The following is a description of a gene set: from publication Xie X, Lu J, Kulbokas EJ, Golub TR, Mootha V, Lindblad-Toh K, Lander ES, Kellis M (PMID 15735639) Comprehensive identification of all functional elements encoded in the human genome is a fundamental need in biomedical research. Here, we present a comparative analysis of the human, mouse, rat and dog genomes to create a systematic catalogue of common regulatory motifs in promoters and 3' untranslated regions (3' UTRs). The promoter analysis yields 174 candidate motifs, including most previously known transcription-factor binding sites and 105 new motifs. The 3'-UTR analysis yields 106 motifs likely to be involved in post-transcriptional regulation. Nearly one-half are associated with microRNAs (miRNAs), leading to the discovery of many new miRNA genes and their likely target genes. Our results suggest that previous estimates of the number of human miRNA genes were low, and that miRNAs regulate at least 20% of human genes. The overall results provide a systematic view of gene regulation in the human, which will be refined as additional mammalian genomes become available. Genes having at least one occurrence of the highly conserved motif M85 STTTCRNTTT in the regions spanning 4 kb centered on their transcription starting sites. This matches the transcription factor binding site V$IRF_Q6 (v7.4 TRANSFAC). species: Homo sapiens Human Gene Set: STTTCRNTTT_IRF_Q6, and this is the list of marker genes: PSME1, ELOA2, HGF, ECM2 (NCBI Gene Id 1842), UBA7, CAPRIN1, BHLHE41, USP44, CCND1, PSMB8, ITGB7, TCIRG1, IL4, DDR2, PTK2, NFIX, RNF31, NAMPT, VGLL4, ARHGAP5, E2F3, SFMBT1, LGALS3BP, MSX1, COL4A1, LSM6, SEPTIN9, DLX4, CCDC6, ETV6, COLCA1, PIGR, ELK4 (NCBI Gene Id 2005), RIGI, KLHL13, TRIM21, LGI1, CDK12, IKZF2, OSM, PIK3R3, COL4A2 (NCBI Gene Id 1284), MED13, DYNLT1, PSMB9, NAV3, IFNB1, IL12RB1, CHGB, PSIP1, EDIL3, NCF1, ZNF366, VAMP5, IL18BP, AMER1, CLDN3, GSX1 (NCBI Gene Id 219409), MRPS18B, IL22RA1, BST2, USF1, ADAM12, YWHAG, PSMA5, HOXA13, CBX4, TCF15, OTX1, OSR2, HPCAL1, CIITA, CTTNBP2NL, EPSTI1, CASP1, ASXL1, MLLT3, SORBS1, FEZF2, SATB2, MOV10, PKN2, MAP3K11, BCL11A, NFATC1, BCL2L1, TCF12, CITED2, IRAG2, ZNF503, SLC15A3, DHX58, TRPM3, NOD2, NRG1, CDK6, JADE2, NR3C2, ISG15, SLC25A28, ALDH1A1, RAPGEF6, ZDHHC14, EIF5A, EVL, CREB1, IFIT2, SRSF6, SLC12A7, HDAC4, LIF, GSC, LRATD2, FAM53B, PPARGC1A, TAP1, TASL, ZBP1, FMR1, MGAT4A (alpha-1,3-mannosyl-glycoprotein 4-beta-N-acetylglucosaminyltransferase A), SLITRK2, IGFBP5, CASZ1, KCNE4, NABP2, CPT1A, PIGV, KIRREL3, HOXB6, TAPBP, DTX3L, TNFSF13B, XAF1, IFIT3, CD200R1, NUB1, MAB21L1, EGFL6, PSMA3, GATA6, PARP9, NPR3, ABHD16A, SYNE2, MSC, FLT3LG, IL27, BATF2, NT5C3A, GRAP2, LRP2, PGM5 (phosphoglucomutase 5), UBD, PSME2, LURAP1L, WNT5A, TMEM229B, IFI44, KIRREL3-AS3, NEDD4, ZEB1, CXCL10, GSDMD, IDO1, SHFL, CDKN2C, TAPBPL, IL17RC, TFDP2, ATXN1, B2M (NCBI Gene Id 567, beta-2-microglobulin), HIP1R, PITX2, PPP1R10, ASPA, USP18, PSMB10, SREK1, LINC00649, CASP7, MXI1, RPL23 (ribosomal protein L23, NCBI Gene Id 9349), PLXNC1, BCOR, PRKD2, ESR1, RBCK1, ARHGEF6, PCGF5, SOX5, CHCHD1, MEIS1